Given this list of marker genes NFATC1 (nuclear factor of activated T cells 1), FOS, NCOR2, HDAC9, HDAC2, EP300, TBX21, NOTCH1, DPY30, RBBP5 (NCBI Gene Id 5929), PHC1, CXCR3, HDAC10, RBBP4, MTA2, GATA3, STAT5A, CBX2, GATAD2B, SNW1, RUNX1, MAML2, CHD3, HDAC4, CBX4, RBBP7, POU2F2 (NCBI Gene Id 5452), IFNG, STAT6, STAT4, HDAC3, MEN1, NFATC2, IL13, IL5, GATAD2A, CBX8, WDR5, KAT2B, IL4, NCOR1, PHC3, HDAC11 (NCBI Gene Id 79885), IL4R, NOTCH2, CHD4, CREBBP, CCL3, MAF (MAF bZIP transcription factor), ETS1, BMI1, POU2F1, RING1, IRF4, HDAC7, STAT1, MTA3, RAD50, HDAC5, PHC2, JUN, SMARCA4, RNF2, HDAC8, KAT2A, MAMLD1, ASH2L, BATF, RBPJ, SCMH1, KLF13, RUNX3, CBX6 (NCBI Gene Id 23466), KMT2A, TBL1X, SATB1, MAML1, MTA1, HDAC1, HDAC6, MAML3 (mastermind like transcriptional coactivator 3), TPST2, TBL1XR1, MBD3 (NCBI Gene Id 8931), IL12RB2 (interleukin 12 receptor subunit beta 2), TNF, STAT5B, YY1, here is a description of the gene set: part of: Developmental Biology studied in species Homo sapiens Reactome Pathway: Differentiation of T cells Thymic seeding progenitors (TSPs), originating from the bone marrow, enter the thymus and pass through six double negative (CD4-/CD8-) stages: DN1, DN2a, DN2b, DN3a, DN3b, and DN4. T cell receptor components are initially expressed in DN3b cells. Double negative 4 (DN4) cells then express both CD4 and CD8 and are designated double positive (DP) cells. DP cells then differentiate into single positive cells: naive (not yet activated by antigen) CD4+ T cells and naive CD8+ T cells. <br>Upon stimulation of the T cell receptor (TCR) by antigen, CD4+ T cells are directed by other external factors, notably cytokines, to differentiate into various types of T helper cells. The different types of T helper cells are characterized by master regulatory transcription factors and secreted effector cytokines: <br>T helper 1 (Th1) cells are regulated by TBX21 (T-bet) and secrete interferon gamma (IFNG). <br>T helper 2 (Th2) cells are regulated by GATA3 and secrete IL4, IL5, and IL13. <br>T helper 9 (Th9) cells are regulated by IRF4 and SPI1 (PU.1) and secrete IL9, IL10, and IL21.<br>T helper 17 (Th17) cells are regulated by RORC isoform t (RORgammat) and STAT3 and secrete IL17A, IL17F, and IL22. <br> T helper 22 (Th22) cells are regulated by TBX21 and STAT3 and secrete IL22, but not IFNG or IL17.<br>T follicular helper (Tfh) cells are regulated by BCL6 and secrete IL21. <br>T regulatory (Treg) cells are regulated by FOXP3 and secrete IL10.